The following is a description of a gene set: ATM signaling in development and disease species: Homo sapiens Human Gene Set: WP_ATM_SIGNALING_IN_DEVELOPMENT_AND_DISEASE, and this is the list of marker genes: AURKB, PPP2CA, MAPK14, HMGN1, STK11, DCLRE1C, RBBP8, SMC1A, MRE11, CDK2, HSPB1, PPP5C, KAT5, CEP63, RNF20, RAD50, RNF8, MAPK13, NFKB1, ATMIN, RIF1, PRKDC, RNF40, MTOR, MDC1, CHEK2, TRIM28, TP53BP1, ATM, IKBKG, HDAC4 (histone deacetylase 4), PPM1D, ATR, CDC25A, NBN, CDK5, CHEK1, RNF168, G6PD, MAPK12, NHEJ1, TP53, BUB1, TSC2, ATF2, MAPK11, LMNB2